The following is a description of a gene set: Human Gene Set: TIEN_INTESTINE_PROBIOTICS_2HR_DN studied in species Homo sapiens Shigella invades the human intestinal mucosa, thus causing bacillary dysentery, an acute recto-colitis responsible for lethal complications, mostly in infants and toddlers. Conversely, commensal bacteria live in a mutualistic relationship with the intestinal mucosa that is characterized by homeostatic control of innate responses, thereby contributing to tolerance to the flora. Cross-talk established between commensals and the intestinal epithelium mediate this active process, the mechanisms of which remain largely uncharacterized. Probiotics such as Lactobacillus casei belong to a subclass of these commensals that modulate mucosal innate responses and possibly display anti-inflammatory properties. We analyzed whether L. casei could attenuate the pro-inflammatory signaling induced by Shigella flexneri after invasion of the epithelial lining. Cultured epithelial cells were infected with L. casei, followed by a challenge with S. flexneri. Using macroarray DNA chips, we observed that L. casei down-regulated the transcription of a number of genes encoding pro-inflammatory effectors such as cytokines and chemokines and adherence molecules induced by invasive S. flexneri. This resulted in an anti-inflammatory effect that appeared mediated by the inhibition of the NF-kappaB pathway, particularly through stabilization of I-kappaBalpha. In a time-course experiment using GeneChip hybridization analysis, the expression of many genes involved in ubiquitination and proteasome processes were modulated during L. casei treatment. Thus, L. casei has developed a sophisticated means to maintain intestinal homeostasis through a process that involves manipulation of the ubiquitin/proteasome pathway upstream of I-kappaBalpha. Genes down-regulated in Caco-2 cells (intestinal epithelium) after coculture with the probiotic bacteria L. casei for 2h. from publication Tien MT, Girardin SE, Regnault B, Le Bourhis L, Dillies MA, Coppée JY, Bourdet-Sicard R, Sansonetti PJ, Pédron T (PMID 16394013), and this is the list of marker genes: WWTR1, ALDH5A1, UFM1, CALD1, CEP76, UBE2D1, PHIP, TIAL1, NCK1, HIC2, GAB2, KLC1, PTGS2, DAB2, HOXA1, SEC23A, STX3, EED, QKI, AK6, PDHX, GGH, EAPP (E2F associated phosphoprotein), PICALM, TIGAR, DIMT1, CLCN4, ZNF512B, RDH11 (retinol dehydrogenase 11), N4BP1, ERCC3, PRCP, INPP5F, TNS3, GINS3, UBE3B, HAUS3, ZFYVE16, GABARAPL1, NOX1, TCAF1, HSPA13, FUBP3, NOC3L, LARS2, E2F8, TMEM165, ZMYND8, CRIM1 (cysteine rich transmembrane BMP regulator 1), MMD, DBN1, RAF1, CLU, FKBP11, OPA1, CEBPD, TCEAL4, FNDC3B, BAZ1A, PPP4R1, ARMCX6 (armadillo repeat containing X-linked 6), SAMM50, BRD8, DKK3, GEMIN2, CKAP4, TAF1A, PPFIA1 (NCBI Gene Id 8500), ATP2C1, JMJD1C, CIRBP (NCBI Gene Id 1153), ETNK1, LRPPRC, RAPGEF2, ARHGAP8, RECQL, CADM1, RCHY1, KLHL7 (kelch like family member 7), FLRT3, EFCAB2, CHMP5, FERMT2, PLXNA1, SOS1, MICAL2, MAP4K4, RESF1, GOLGA7